Given this list of marker genes SLC1A2, SLC1A1, SLC1A3, NTSR1, GFAP, here is a description of the gene set: species: Homo sapiens The process in which D-aspartate, the D-enantiomer of the anion of (2R)-2-aminobutanedioic acid is transported across a lipid bilayer, from one side of a membrane to the other, by means of some agent such as a transporter or pore. Human Gene Set: GOBP_D_ASPARTATE_TRANSMEMBRANE_TRANSPORT